Given this list of marker genes SRD5A1, CYP19A1, HSD17B11, SPP1 (secreted phosphoprotein 1), HSD17B6, here is a description of the gene set: Human Gene Set: GOBP_ANDROGEN_CATABOLIC_PROCESS studied in species Homo sapiens The chemical reactions and pathways resulting in the breakdown of androgens, C19 steroid hormones that can stimulate the development of male sexual characteristics.